Given this list of marker genes IQGAP3, CACNA1H, MEOX1, BRD7 (NCBI Gene Id 29117), PKP1, IL5, DMTF1, NDUFB10, APBB1IP, DMRTB1, GALK2, ECPAS, PNKP, GP9, GRIA3, SLC22A5, MRPL13, MPHOSPH10, MRPS21, LUC7L3, OGT, ASAH1 (N-acylsphingosine amidohydrolase 1), OTULINL, PDCD2, BMP2K, PHKG1, NCOA2, HTR2C, CLGN, PBX3, H2BC18, ECE1, RASGRP2, PPP6C, FCRLA, INTS8, OGFOD2, BAIAP2, ADAMDEC1, ARPC5L, PKHD1, TDRP, SCN10A (sodium voltage-gated channel alpha subunit 10), IMPA1, SEC11A, HCRT, PPIH, SCN1A, CDR2L, DNAJA1, HAX1, MEF2D, POLR2H, GBA2, PSMB1, GPN3, DNAJA3, IL1RN, EGLN2, MBL2, NTN1, LCAT, RPA3, NSMCE1, DNAJB1, CD3E, ATP6V1B2, MSRB1, SIGLEC1 (NCBI Gene Id 6614), RUNX1T1 (NCBI Gene Id 862), SCP2, IRF2BP1, MC5R, DNAJC9, CDH13, RP9, SCX, CENPA, SGPP1 (NCBI Gene Id 81537), PMM2 (phosphomannomutase 2, NCBI Gene Id 5373), KIF3B, LGALSL, ARL2 (ADP ribosylation factor like GTPase 2), CDON, MKNK1, RBM26, FIP1L1, B3GAT3, AXIN1, MRPS25, ACVRL1, AKIRIN2, NFU1, IGF1, COPE, RNF34, GSC, SHF, H3C7, GNB1, DSTN, ANKZF1, DNAJB2, LEPROT, NFE2, ARF1, BARX1 (NCBI Gene Id 56033), POLR2J, ADAMTS1, EEF1AKMT1, CSTF2, PRR15, RBBP4, GLMP, MTARC2, CYBB, NEDD8, ARX, RACK1, NOP58, CLOCK, ATF2, DCUN1D5 (defective in cullin neddylation 1 domain containing 5), ARG1, RFK, LRRC58, ATP6V1H, RAB4A, SAA1, IKBKB, BPIFA2, MATR3, SLC22A6, MAT2B, PCBD2, RUNDC3A, METTL18, FZD6, EMP3 (epithelial membrane protein 3 (MAM blood group)), FLT3, GSTT2, GJB2, SCAMP1, CLCNKB, NT5DC3, BMP8A, H1-4, TMEM245, MYRF, CNN2, IRS2, GABPA, MIF, CLEC4D, MATN3, PGAM1, ABRACL, F8, CNP, SEMA3F, NUTF2 (NCBI Gene Id 10204), CD40LG, ANLN, GPM6B, HPGD, ATP5F1A, BUD31, DNAJA2, REXO5, PTP4A2, MYCBP, ARAP3, SERTAD1, RGS19, HPN, NPPC, GABARAPL1, KLHL21, COPS3, NRG3, CHPT1, LY75, PRMT3, PKNOX1, HSD17B11, GJA1, ANKRD10, MYO1C, POLR2F, HMGB2, FBXO15, DMRT1, KIF3C, IL9, SH3BGR, GCDH, PREB, GATA1, GLRB, CISD1, here is a description of the gene set: Differentiation of naive CD8 T cells into cytotoxic effector cells requires three distinct signals- antigen (signal 1), costimulation -B7-1 (signal 2) and cytokine, either interleukin-12 or interferon-a/b (signal 3). Interaction of naive CD8 T cells with antigen and B7-1 programs cell division and proliferation whereas the presence of cytokines- IL-12 or IFNa/b promote survival, differentiation and memory establishment. In the absence of signal 3, the cells interacting with antigen/B7-1 undergo tolerance induction. The objective of this study was to elucidate the mechanisms how the provision of signal 3 promotes differentiation and averts tolerance induction in CD8 T cells. Trichostatin A is a pharmacological agent that inhibits histone deacetylase activity, hence regulating chromatin structure and gene expression and differentiation in many cell types. Gene signature profiles of IL-12, IFNa/b and trichostatin A stimulated cells were compared to elucidate the molecular mechanisms of gene regulation. Oligonucleotide microarray analysis is carried out to determine the extent and molecular nature of the CD8 T cell differentiation program induced by IL-12 or IFNa/b in concert with antigen and B7-1 signal. from publication Agarwal P, Raghavan A, Nandiwada SL, Curtsinger JM, Bohjanen PR, Mueller DL, Mescher MF (PMID 19592655) studied in species Homo sapiens Genes up-regulated in comparison of unstimulated CD8 T cells at 24 h versus CD8 T cells at 24 h after stimulation with antigen-B7-1. Human Gene Set: GSE15930_STIM_VS_STIM_AND_IFNAB_24H_CD8_T_CELL_UP